The following is a description of a gene set: from publication Cui A, Huang T, Li S, Ma A, Pérez JL, Sander C, Keskin DB, Wu CJ, Fraenkel E, Hacohen N (PMID 38057668) species: Mus musculus Cytokines mediate cell-cell communication in the immune system and represent important therapeutic targets. A myriad of studies have highlighted their central role in immune function, yet we lack a global view of the cellular responses of each immune cell type to each cytokine. To address this gap, the authors created the Immune Dictionary, a compendium of single-cell transcriptomic profiles of more than 17 immune cell types in response to each of 86 cytokines (>1,400 cytokine-cell type combinations) in mouse lymph nodes in vivo. A cytokine-centric view of the dictionary revealed that most cytokines induce highly cell-type-specific responses. For example, the inflammatory cytokine interleukin-1β induces distinct gene programmes in almost every cell type. A cell-type-centric view of the dictionary identified more than 66 cytokine-driven cellular polarization states across immune cell types, including previously uncharacterized states such as an interleukin-18-induced polyfunctional natural killer cell state. Mouse Gene Set: CUI_B_CELL_IFNB_RESPONSE_UP Genes positively differentially expressed in cell type: B cell upon treatment with cytokine: IFN-β in mouse lymph nodes in vivo., and this is the list of marker genes: Treml2, Irf1, Pole4, Tcof1, Irgm1, Anp32b, Psmb10, Ffar1, Uqcc2, Man2a1, Nit2, Sell, Tomm40, Znhit6 (NCBI Gene Id 69746), Daxx, Ifitm3 (NCBI Gene Id 66141), Lsg1, Nmral1, 9930111J21Rik2, Vps37b, Xrn2, Mif, Ssrp1, Zeb2, Plac8, Ifi47, Max, Eif4a1, Ebna1bp2, Shmt2, Nmi, Cmpk2, Rbm8a, Hnrnpab, Naa20, Nifk, Psma4, Rtp4, Pno1, Ogfr, Taldo1, Hnrnpd, Mat2a, Hck, Rasa4, Tlr7, Cdk6, Eef1e1 (eukaryotic translation elongation factor 1 epsilon 1), Cycs, Usp18, Mndal, Myc, Ifi213, Srm, Nudc, Ddx39a, Dnajc7, Psmb9, Rsl24d1, Cct8, Lpxn, Cd86, Hspa8, Sidt1, Ddx18, Mrto4, Selenow, Nlrc5, Ppan, Ascc3, Ranbp1, Cited2, Ifi208, Etf1, Slfn8, Parl, Rbmxl1, Hsp90ab1, Tpst1, Arhgap30, Arf1, Timm10, Cacybp, Cct3, H2-T24, Ly6a, Eif5a, Brix1, H2-T22, Rab5c, Exosc1, Nhp2, Ppa1, Nopchap1, Srsf3, Dnaja1, Utp14a, Tasor2, Oasl1, Gem (GTP binding protein overexpressed in skeletal muscle), Oas2, Map3k8, Ube2l6, Prdx3, Snrpa1, Rsad2, Ifi35, Coro2a, Ube2v2, Mrpl30, Ltv1, Slamf7, Gbp5, Ppid, Keap1, Ythdf2, G3bp1, Psme1, Parp9 (NCBI Gene Id 80285), Aida, Clec2d, Lap3, Pa2g4, Uba7, Naa25, Gpr65, Tor3a, Ifi214, Nars1, Tial1, Hsph1, Ppp1r14b, Bst2, Samd9l, Itm2b, Irf7 (interferon regulatory factor 7), Tmem184b, Cflar, Chmp4b, Ubb, Cct2, Gpatch4, Slfn5, Dnttip2, Npm1, Trim12c, Rcc2, Ifit3b, Smg7, B4galt5, H2-T23, Hmgn3, Larp1, Grwd1, Capza2, Dhx58, Hspa5, Cybb, Sp110, Pnpla2, Nme1, Ppia, Rae1, Hspa9, Set, Dnaja2, Sp140, Ndufa12, Gbp2, Mcm6, Snx2, Slc25a5, Cnp, Parp11, Ddx60, Cbfa2t3, Wdr43, Dctpp1, Parp10, Oas1a, Ssbp1, Cnbp, St13, Sdc3, Rrs1, Eif2s2, Esf1, Ftsj3, Trim30a, Oasl2, Etnk1, Dkc1 (dyskeratosis congenita 1, dyskerin), Tap1, Ncl, Apobec1, B2m, Runx3, Herc3 (hect domain and RLD 3), Herc6, Ifi209, Trim30b, Tent5a, BC051226, Mphosph10, Rigi, Ctsc, Srsf7, Nampt, Znfx1, Stip1, Tspo, Phc2, Nolc1, Tapbp, Cnot6l, Mycbp2, Phf11a, Pdcd10, Ubr4, Epsti1, Vps54, Prmt3, Serpina3g, Cd69, Atp5mc1, Psma5, Idh3a, Cct5, Aprt, Rrp15, Tmbim6, Mx1, Sf3b3, Plekhf2 (NCBI Gene Id 93778), Slfn2, Pfdn2, Ddx21, Psme2b, Vars1, Larp4, Trim12a, Carmil1, Bbx, Slc38a2, Xrn1, Camk2d, Icam1, Fxr1, Laptm4a, Acsl5, Nsmaf, Zbp1, Pdia3, Gbp9, Ifit3, Slc7a1, Gns, Pcgf5, Tmem243, Irf8, Txn2, Ly6e, Xaf1, Tbc1d1, N4bp1, Alkbh1, Hspa1a (heat shock protein 1A), Psmb8, Kctd14, Ctss, Mov10, Arfgef1, Trafd1, Oas3, Chordc1 (cysteine and histidine rich domain containing 1), Psmd7 (proteasome (prosome, macropain) 26S subunit, non-ATPase, 7), Ppig, Hspe1, Gart, Tmed5, Cxcl10, Hsh2d, Cct7, Gnl3, Camkk2, Asb13, Aen, Plgrkt, Stat2, Nop56, U2af1, Lyn, Ifi203, Psme2, Ruvbl2, Hnrnpf, Psmg4, Ly86, Pum3, Vrk1, Cd47, Fam111a (family with sequence similarity 111, member A), Uvrag, Dtx3l, Mrps18b, Eif3b (eukaryotic translation initiation factor 3, subunit B), H2-K1, Snrpe, Tapbpl, Sdad1 (SDA1 domain containing 1), Odc1, Psmd11, Isg15, Rfc3, Pgd, Hsp90aa1, Ldha, Bcap29, Hspd1, Igtp, Rrp9, Hmox2, Ogfrl1, Atp5f1b, Srsf2, Nsd3, St3gal6, Prmt1, Clic4, Phf11b, Timm8a1, Utp18, Ifi27l2a, Irf9, Fkbp4, Kpnb1, Nt5c3, Ifit1bl1, Psma7, Snrpd3, Eif2s1, Cnn3, H2-D1, Eif5b, Jaml, Mgat1 (mannoside acetylglucosaminyltransferase 1), Socs1, Tcf4, Pml, Tomm20, Fbl, Znrd2, Mpeg1, Nop58, Serbp1, Cops7a, Hspa1b, Dbnl, Nup210, Gtpbp4, Evi2a, Rabepk, Nr2c2ap, Evl, Eif3g, Ybx3, Mybbp1a, Tent4a, Eif4a3, Ms4a4c, Cxcr5, Calhm6, Svbp, Btf3, Sub1, Igkc, Rsl1d1, Gar1, Rbm3, Marchf5, Trim30c, Ccnd2, Tor1aip1, Arf4, Gbp4, Zup1, C1qbp, St6galnac4, Adar, Dek, Zcchc2, Slc25a28, Slc25a22, Ifit2, Ran, Zc3hav1, Tmsb10, Eif6, Baz1a, Lyar, Morc3 (microrchidia 3), Setdb2, Dph5, Ifih1 (interferon induced with helicase C domain 1), Rnf114, Usp25, Casp4, Smagp, Srsf6, Shisa5, Rnf213, Zfp593, Snu13, Mettl1, Eif3c, Samhd1, Psma3, Ddx39b, Snrpd1, Gramd2b, Ms4a4b, Phgdh, Ifi206, Ifrd1, Ifit1 (NCBI Gene Id 15957), Cep57, Pkib, Ptma, Phip, Gbp7, Trim14, Rbx1, Eif2ak2, Ddx24, Isg20, Sdc4, Rnf139, Peli1, Sp100, Cdv3, Fnbp4, Helz2, Zfp800, Kansl2, Plaat3, Lsm6, Stat1, Mitd1 (NCBI Gene Id 69028), Tcstv4, Nmd3, Lgals9, Rpf2, Trim30d, Smchd1, Eif1a, Rars1, Apex1, Lgals3bp, Fam136a, Parp14